The following is a description of a gene set: species: Homo sapiens Human Gene Set: HALLMARK_TGF_BETA_SIGNALING from publication Liberzon A, Birger C, Thorvaldsdóttir H, Ghandi M, Mesirov JP, Tamayo P (PMID 26771021) Genes up-regulated in response to TGFB1., and this is the list of marker genes: IFNGR2 (interferon gamma receptor 2), ID1, TGFB1, LTBP2, SMAD6, MAP3K7, SKI, PPP1CA, SMAD3, BMPR2, KLF10, WWTR1, TGFBR1, HDAC1, NOG, TJP1, SMURF1, BCAR3, THBS1, SMAD1, UBE2D3, APC, BMPR1A, HIPK2, PPP1R15A, ID2, LEFTY2 (left-right determination factor 2), CDKN1C, PPM1A, SMURF2 (NCBI Gene Id 64750), XIAP, SMAD7, ACVR1, SERPINE1, ENG, RHOA, BMP2, FURIN, FKBP1A, TGIF1, CDK9, FNTA, CTNNB1, RAB31, ARID4B, SLC20A1, TRIM33 (NCBI Gene Id 80027), SPTBN1, SKIL (SKI like proto-oncogene), JUNB, PMEPA1, ID3, NCOR2, CDH1